Given this list of marker genes MIR20A, MIR204, MIR20B, MLH1, PAN2, DCP2, PLEKHN1, PNLDC1 (NCBI Gene Id 154197), TTC5, CAPRIN1, NANOS3, RBMY1J, MIR106A, PUM2, EIF4ENIF1, MIR146A (NCBI Gene Id 406938), TRA2A, MIR337, SNRNP70, ZC3H12A, CNOT9, MIR320A, MIR125A, PRPF19, HNRNPD, RBMXL1 (NCBI Gene Id 494115), NCBP2, CNOT4, MIR23A, MIR625, MIR200B, RBMY1A1, TENT4B, CIRBP, MIR135B, MIRLET7B, AGO2, MEX3D, CELF1, TARDBP, PNPT1, FXR1, ELAVL1, MIR145, MIR210, MIR27A, MIR517C, CNOT7, MIR137, MIR544A, MIR485 (NCBI Gene Id 574436), MIR181B1, QKI, STH, NUP98, PABPC1, ROCK2, SAMD4A, DIS3, MIR181C, UPF1, METTL14, MIR519D, CSDE1, RBM3, MIR151A, PATL2 (PAT1 homolog 2), DCP1B, MIR181A2, MIR19B1, MIRLET7A1, MIR340, POLR2G, MIR365A, MIR18A, TNKS1BP1, MIR483, RBM24, MIR223, YTHDF1, PARN, MIR9-1, RBMY1D, AGO3, ZC3H12D, CNOT3, CNOT10, CNOT6L, PRMT5, MIR19A, SLC39A5, MIR326, MIR103B1, MIR329-1, SNW1, FTO, MIR214, DHX9, MIR106B, MIR185, MIR149, HMX2 (NCBI Gene Id 387716), PAN3, TOB1, PIWIL2, GTSF1, MIR130B (NCBI Gene Id 406920), CNOT11, MIR200C, MIR206, MIR191, NOCT, MIR181D, MIR497, MIR302A, MIR203A (microRNA 203a), MIR142, CELF4, MIR128-1, MIR195, TNRC6A, MOV10, MIR424, METTL3, MIR140, UPF3A, ZC3HAV1, EXOSC10, TRIM71, MIR211, GIGYF2, YBX1, MIR193A, MIR302C, NANOS2, MIR562, DND1, CLNS1A, MIR133A1, MIR486-1, MIR93, MIR190B, MIR4286, CPEB3, MIR564, AGO1, ALKBH5, SYNCRIP (synaptotagmin binding cytoplasmic RNA interacting protein), CNOT2, MIR501, METTL16, PRR5L, PIWIL1, MIR30B, NT5C3B, MIR199B, MIR885, TUT7, CNOT1, UPF3B, MIR495, PATL1, MIR665, ZFP36L2 (ZFP36 ring finger protein like 2), MIR491, AGO4, PDE12, NCL, MIR96, MIR34B, MIR655, CNOT6, PRDX6, IGF2BP1, MIR24-1, TNRC6C, PABPN1L, WDR77, RBMY1E, ROCK1 (Rho associated coiled-coil containing protein kinase 1), MIR517A, MIR708 (microRNA 708), MIR373, MIR125B1, RC3H1, DIS3L2, RIDA, RBMY1F, DCP1A, DHX36, KHSRP, MIR98, MIR26B, NANOS1, SAMD4B, MIR29B1, MIR27B, TUT4, YTHDF3, TENT4A, CDC73, ZFP36, DAZAP1, CNOT8, MIR192, MIR519A1, MIR520C (NCBI Gene Id 574476), THRAP3 (thyroid hormone receptor associated protein 3), ZFP36L1, MIRLET7E, MIR543, GTPBP1, NCBP1, MIR663A, MIR342, FXR2, YTHDF2, MIR212, TNRC6B, CELF3, MIR130A, RBMX, MIR608, BTG2, MIRLET7C, HNRNPU, MIR1-1, PUM1, RBMY1B, PAIP1, CCNB1, RC3H2, DCPS, TRA2B, MIR100, MIR423, LSM1, here is a description of the gene set: species: Homo sapiens Human Gene Set: GOBP_POSITIVE_REGULATION_OF_MRNA_METABOLIC_PROCESS Any process that activates or increases the frequency, rate or extent of mRNA metabolic process.